The following is a description of a gene set: studied in species Homo sapiens The chemical reactions and pathways involving a diphosphoinositol polyphosphate, 1,2,3,4,5,6-cyclohexanehexol with one or more diphosphate groups and multiple monophosphate groups attached. Human Gene Set: GOBP_DIPHOSPHOINOSITOL_POLYPHOSPHATE_METABOLIC_PROCESS, and this is the list of marker genes: NUDT11, NUDT3, NUDT10, NUDT4, NUDT4B